The following is a description of a gene set: species: Mus musculus Mouse Gene Set: chr4D2, and this is the list of marker genes: Gm12887, Snora44, Gm12925, Laptm5, Phactr4, Map7d1, Gm12945, Gm13214, Mir697, Ebna1bp2, Rbbp4, Stx12, Rnf19b, Epb41, Fgr, Gm25261, Foxo6os, Gm12855, Hpca, Gm12922, Bsdc1, Or13p8, Gm12867, Slfnl1, Atp6v0b (NCBI Gene Id 66370), Gm12853, Pigv, Gm12958, Or13p5, Yars1, Ptafr, Tmem39b, Snhg3, Rnu11, Sdc3, Gm12915, Hmgb4os, Zdhhc18, Gm10300, Frg2f1, Med18, Cdca8, Zbtb8os, Hdac1, Tlr12, Stk40, Snhg12, AU022252, Trnau1ap, Gm12936, Zfp691, Gm12897, Gnl2, Rps15a-ps4, Utp11, A3galt2, Rpa2, Azin2, Gm12874, Gm12976, Gm24762, Gm12944, Meaf6, Ppie, Gm12888, Kdf1, Mfsd2a, Trim62, Gm15904, Gm24161, Mir698, B4galt2, Gm25604, Svbp, Gm13259, Sesn2, Dlgap3, Gm12865, Nfyc, AU040320, Gm12866, 5730409E04Rik, Ago1, Scmh1, Ppp1r8, Foxj3, Txlna, Rlf, Snora61 (NCBI Gene Id 100217440), Szt2, Marcksl1, Or13p4, Gm23055, Taf12, Dph2, Gm25323, Yrdc, Gjb5, Cldn19, Tfap2e, Gmeb1, Gm13063, Tekt2, Or10ak11, Pum1, Gm12864, Foxo6, Arid1a, Zmym4, Hivep3, Tmco2, Gm13033, Gm25788, Gm12901, Col16a1, Cdc20, Elovl1, Dnali1, Smap2, Gm22767, Khdrbs1, Tmem222, Eya3, Gm12882, Serinc2, A930004J17Rik, Gm12924, Rhbdl2, Gm12978, Epha10, Mycl, Bmp8a, Gm24678, Zc3h12a, Ago3, 4933421A08Rik, Tmem35b, Heyl, Rimkla, Ppih, Zmym6, Smim12, Mir7227, Mir5122, Gm12841, Fam229a, Ncdn, Srsf4, Or10ak12, Rims3, Mir7016, Gm24352, Nt5c1a, 2610028E06Rik, Snip1, Zfp362, Ctps1 (cytidine 5'-triphosphate synthase 1), A930031H19Rik, Snora73a, P3h1, Gm17244, Gm12857 (NCBI Gene Id 674657), 4933407E24Rik, Nhsl3 (NHS like 3), Oxct2b, Gm12967, Gm13215, Fhl3, Hyi, Nudc, Tmem125, Gm12956, Gpatch3, Ppt1, Zbtb8a, Ndufs5, Phc2, Kpna6, Sh3d21, Gm25600, Zmynd12, Psmb2, Gm12891, Klf17, Gm26162, Gm12844, Snora73b, Gm12980, Matn1, Sfn, Gm12966, Wasf2, Gm23382, Gm12963, 1110065P20Rik, Ahdc1, Fam76a, 1700041M05Rik, 9530002B09Rik, Gm12955, Sf3a3, Mir6398, Fam167b, Gm12842, Eva1b, Or13p10 (NCBI Gene Id 258312), Xkr8, Gm12856, Slc9a1, Ythdf2, Gpr3, Gm12860, Gm16080, Col9a2, Zscan20 (zinc finger and SCAN domains 20), Snord99, Gm12977, Spocd1, Wdtc1, Ak2, Rragc, Gm12957, Fabp3, Gm13252, Gm12892, Nkain1, Trnp1, Oscp1, Gm12970, Edn2, Or10ak7, Gm12876, Lao1, Gm12900, Tssk3, Ptprf, Zcchc17, Mir7119, Dnajc8, Hcrtr1, Cap1, Gm831, Gm12923, Zmym1, Ptpru, Ago4, Hpcal4, Zfp69, Or13p9-ps1, Themis2, Zbtb8b, Csmd2 (NCBI Gene Id 381557), Med8, Gm12859, Rab42, Gm12933, Mycbp, Tent5b, Rpl28-ps3, Fndc5, S100pbp, Hmgb4, Gm22154, Gm12917, Tinagl1, Grik3, E330017L17Rik, Gja4, Smpdl3b, Dmap1, Ipo13, Cited4, Mir30c-1, Macf1, 1700125G02Rik, Gm12973, Gm12974, Klf18, Pou3f1, Or10ak8, Pabpc4, Sfpq, Map3k6, Lck, Gm12972, Gm2164, Rps6ka1, Kcnq4, Ppcs, Trit1, Tmem269, Pef1, Ldha-ps2, 1700003M07Rik, Gm12943, Ybx1, Snora16a, Iqcc, Gm13213, 1700057H15Rik, Mecr, Tmem200b, Airim, Exo5, Ptp4a2, Mtf1, Atp5if1, Tie1, Or10ak16, Tmem54, Gm10570, Clspn, Ermap, CK137956, Guca2a, 2610528J11Rik, Maneal, Mir7017, Gm25270, Gm13257, Inpp5b, 1700121C08Rik, Or10ak9, Gm22221, Mir8119, Gm12948, Gm12880, Gm28874, Gm24621, Artn, Mir7226, Dcdc2b, Gm12927, Gm12969, Zmpste24, Gm12886, Adprs, Ldc1, Adgrb2, Guca2b, Or10ak13, Ccdc28b, Gm12904, Kdm4a, Gjb3, Rspo1, Mpl, Eif3i, Ccdc30, Gm12947, Or10ak10-ps1, Gm22523, Gm23845 (NCBI Gene Id 115489377), Sec61g-ps3, Gpn2, 4933435F18Rik, Gm13022, Sytl1, Csmd2os, Gm12871, A630031M04Rik, Gm23540, Oprd1, Sync, Trappc3 (NCBI Gene Id 76909), Gm12930, Gm12916, Csf3r, Cfap57, Slc6a9, Gm12877, Ccdc24, Or13p3, Nr0b2, Col8a2, Bmp8b, Rcc1, Oxct2a, Snrnp40, Lsm10, Gjb4, Gm12992, Gm22660, Mrps15, Thrap3, 1700112K13Rik, 4933427I04Rik, Slc2a1, Tmem234, Akirin1, Or10ak14, 9530034E10Rik (RIKEN cDNA 9530034E10 gene), St3gal3, 1700086P04Rik, Cd164l2, Snord85, Ftl2-ps, Mir7015